Given this list of marker genes PDZRN4, HMG20A, EIF4G1, MEA1, ZNF184, CPEB4, FAM98B, RAPH1, COG3, NAA20, ITGB1BP1, ZSCAN29, INO80B, RAP2C, PYM1, ZNF22-AS1, MAPK8IP3, ITGB3BP, GTF2A2, NDUFS1, BTAF1, ITFG1, FUZ, AP5M1, SHC1, RPS18, ZCRB1, BATF2, DIABLO, PPIE, DCTN5, AP1B1, FERMT3, PPME1, GABARAPL2, TIGD6, TRMT1, STK4, SEC24C (SEC24 homolog C, COPII coat complex component), BCL2L1, CLDN7 (NCBI Gene Id 1366), SDHD, ERI2, PRCP, CLDN5, FAM174A, AKT1S1, ARHGAP1, EN1, NFYA, NKIRAS2, P3H1, NUDT12, CCP110, PDRG1, TBC1D17, AP2S1, PIH1D2, FBXL9P, FBXO36, TIGD1, PSMC2, PSMC6, C1orf210, CRB3, TUBGCP4, MYL6B, CLEC18C, PHKB, UBE2L3, MARK3, FBXW9, POMP, APOLD1, CKS1B, MTBP, GGT7, EXOC5, ZNF384, TIMM8B, KLHDC3, MED15, INTS11, ZDHHC5, ATP5F1A, RAB11B, DPP8, CRK, PRKAG2, WDR74, DHX30, PTRH2, LINC03124, CDC45, CGGBP1, CALU, LRRC41, KRTCAP2, DNAJA2, KAT7, SNF8, NRAS, AP1M1, COX8A, PALB2, NIPBL, RAB2A, JOSD2, MED8, MTPN, IMP3, PURB, PPP2R2C, FANCD2, SENP7, PSMD12, MRPL3, SZT2, IMMT, HERC4, GART, RFC4, DNAJC24, SON, NEDD1, DDIAS, ACVR2A, IL2RG, CDK13, UBR1, NECAP2, MAPKAP1, HMGA1 (high mobility group AT-hook 1), CHID1, INSIG2, LMAN2, GTF3C2 (NCBI Gene Id 2976), KMT5A, BAG6, TRIM46, OARD1, ZNF653, GDE1, NKAPD1, CREBZF, TMEM187, GFUS, PSMC1, TOMM40, FAF2, RBM22, GOLGA1, EIF5A, ZNF410, USP32, LYPLA2, SYVN1, GTF3C1, BMP2K, TMEM208, EXTL2, AAK1, ARL5B, DDX5, SMS, ZNF408, FBXO3, LLPH, CBARP, CHERP, CSGALNACT2, MTX2, PEX11A, GNL3L, PCYT1A, ZNF22, SCO1, MPZL3, ADPRM, CCDC25, DNAJC7, SIRT6, POLL, OGG1, NF1, ITM2C, UBAC1, ACP2, FMR1, TCF7, ZNF322, DCDC1, SUPT5H, SAMD8, TBX6, PRPF18, TMEM9B, VMP1, EMC3 (ER membrane protein complex subunit 3), MRPL13, INTS3, ZBTB11, REXO5, TSPAN31, SRP19 (signal recognition particle 19), UBE2N, ZNF23, CCDC174, EPN1 (NCBI Gene Id 29924), TRIM44, RPL37, HAT1, TTPAL, LRRFIP1, SLC30A7, TBCC, SMUG1, WDR93, FBXO22, TMEM53, VPS52, NUDT21, DDOST, ACTR2, UGGT2, ARCN1, TRO, RPL19, SEC13, LSM5, STX12, PDE12, UQCRH, TENT2, EEF1B2 (NCBI Gene Id 1933), NUP214, DPCD, IQCK, PRKACB, STOML2, PPIG, SRBD1, FOXH1, SYT5, CCDC71, SNRPB, TRAF7, CPSF3, UFD1, PPHLN1, TUFM, IPO4, NR1H2, C1orf50, CEP95, ELAVL1, here is a description of the gene set: Genes having at least one occurrence of the motif NNNNCCGGAARTNN in the regions spanning 4 kb centered on their transcription starting sites. This matches the ELK1 transcription factor binding site V$ELK1_02 (v7.4 TRANSFAC). species: Homo sapiens Human Gene Set: ELK1_02